Given this list of marker genes POLD4, CETN2, RFC1, RAD23B, RPA1, POLE4, POLD1, GTF2H1, GTF2H3, RFC5, LIG1, RFC2, ERCC2, ERCC8, CCNH, ERCC3, CDK7, RFC4, MNAT1, XPC, DDB1, CUL4A, CUL4B, GTF2H4, GTF2H2, POLE3, DDB2, XPA, ERCC6, GTF2H2C, RPA3, ERCC5, RFC3, RBX1, GTF2H5, POLD2, RPA2, POLE2, POLE, PCNA, POLD3, RAD23A, ERCC1, ERCC4, here is a description of the gene set: species: Homo sapiens Human Gene Set: WP_NUCLEOTIDE_EXCISION_REPAIR Nucleotide excision repair